The following is a description of a gene set: Human Gene Set: GOBP_LEUKOTRIENE_B4_METABOLIC_PROCESS The chemical reactions and pathways involving leukotriene B4, a leukotriene composed of (6Z,8E,10E,14Z)-eicosatetraenoic acid having (5S)- and (12R)-hydroxy substituents. studied in species Homo sapiens, and this is the list of marker genes: CYP4F2, CYP4F12, CYP4A11, PTGR1, CYP4F3